The following is a description of a gene set: from publication Yevshin I, Sharipov R, Kolmykov S, Kondrakhin Y, Kolpakov F (PMID 30445619) Human Gene Set: HSF4_TARGET_GENES Genes containing one or more binding sites for (HSF4) in their promoter regions (TSS -1000,+100 bp) as identified by GTRD version 20.06 ChIP-seq harmonization. species: Homo sapiens, and this is the list of marker genes: H2BC21, H2AC8, MALAT1, H2BC7, MLH1, H4C2, H4C16, H4C3, RNU5A-1, RNU2-2P, RNU11, TSPYL4, NPM1, H4C8, H2AC20, WDR74, H2AC7 (H2A clustered histone 7), EPM2AIP1, H2BC8 (H2B clustered histone 8), H3C7, RNU5B-1, H2BC9 (NCBI Gene Id 8345)